The following is a description of a gene set: Any process that results in a change in state or activity of a cell or an organism (in terms of movement, secretion, enzyme production, gene expression, etc.) as a result of an interleukin-18 stimulus. species: Mus musculus Mouse Gene Set: GOBP_RESPONSE_TO_INTERLEUKIN_18, and this is the list of marker genes: Il18r1, Akt1, Il18, Ocln, Cyld, Nlrp6, Il18rap, Pdgfb, Ifng, Ticam2, Casp4, Ripk2, Cldn1, Pik3r1